The following is a description of a gene set: studied in species Mus musculus from publication Mikkelsen TS, Hanna J, Zhang X, Ku M, Wernig M, Schorderet P, Bernstein BE, Jaenisch R, Lander ES, Meissner A (PMID 18509334) Genes with intermediate-CpG-density promoters (ICP) bearing the tri-methylation mark at H3K27 (H3K27me3) in MCV6 cells (embryonic fibroblasts trapped in a differentiated state). Mouse Gene Set: MIKKELSEN_MCV6_ICP_WITH_H3K27ME3 Somatic cells can be reprogrammed to a pluripotent state through the ectopic expression of defined transcription factors. Understanding the mechanism and kinetics of this transformation may shed light on the nature of developmental potency and suggest strategies with improved efficiency or safety. Here we report an integrative genomic analysis of reprogramming of mouse fibroblasts and B lymphocytes. Lineage-committed cells show a complex response to the ectopic expression involving induction of genes downstream of individual reprogramming factors. Fully reprogrammed cells show gene expression and epigenetic states that are highly similar to embryonic stem cells. In contrast, stable partially reprogrammed cell lines show reactivation of a distinctive subset of stem-cell-related genes, incomplete repression of lineage-specifying transcription factors, and DNA hypermethylation at pluripotency-related loci. These observations suggest that some cells may become trapped in partially reprogrammed states owing to incomplete repression of transcription factors, and that DNA de-methylation is an inefficient step in the transition to pluripotency. We demonstrate that RNA inhibition of transcription factors can facilitate reprogramming, and that treatment with DNA methyltransferase inhibitors can improve the overall efficiency of the reprogramming process., and this is the list of marker genes: Sectm1a, Asb2, Tbata, Odf1, Etv2, Sacs, a, Or2b11, Nrl, Accsl, Prok1, Gprc5d, Tfap2b, Kcnk10, Lefty1, Vtn, Tmem181b-ps, Aipl1, Sox17, Prss16, Lingo4, Col11a2, Pdyn, Kcnj5, Lypd10, Pnoc, Fndc9, Fam149a, Optc, Scn4a, Krt73, Ffar3, Adm2, Cd7, Gas2l2, Alox12e, Pou2f2, Or4d2, Mov10l1, Arhgap9, Fut1, Pvalb, H2-T3, Cux2, Rtbdn, Nkx2-6, Slc2a10, Kcng4, Pak6, Kcnab1, Or4d2b, Lpo, Gkn3, Slc14a1, Pcdh12, Bsx, Chrnb4 (NCBI Gene Id 235389), Tnf, Chrng, Coro1a, Wnt8b, Th (NCBI Gene Id 21823), Pik3cd, Apc2, Cd40, Ncan, Akp3, Ifnk, Iqcj, Fgl2, Ren1, Spaca7, Sox6, Cldn14, Dppa1, S100z, Islr2, Fgf10, Pax5, Shank2, Ggt7